Given this list of marker genes GGT1, CYSLTR1, CYSLTR2, GGT5, DPEP2, DPEP1, here is a description of the gene set: part of: Anti-inflammatory response favouring Leishmania parasite infection The Leukotriene C4 (LTC4) is a metabolite of arachidonic acid that can be produced intracellularly or extracellularly. LTC4 binds an unidentified, intracellular cysLTR. Signalling downstream LTC4 cysLTR binding has been associated with the production of IL4, independent of the GPCR associated heterotrimeric protein Gq (Bandeira Melo et al. 2002). Reactome Pathway: LTC4-CYSLTR mediated IL4 production studied in species Homo sapiens